The following is a description of a gene set: VEGFR2 mediated vascular permeability studied in species Homo sapiens Human Gene Set: REACTOME_VEGFR2_MEDIATED_VASCULAR_PERMEABILITY, and this is the list of marker genes: JUP, CDH5, CALM1, RAC1, CAV1, PAK1, MLST8, AKT2, HSP90AA1, THEM4, PDPK1, TRIB3, VAV3, NOS3, RICTOR, AKT1, CTNNA1, PRR5, MTOR, VAV1, AKT3, PAK3, CTNNB1, VAV2, CTNND1, MAPKAP1, PAK2